Given this list of marker genes SLC39A4, TNFRSF11A, FOS, SLC39A5, SP1, BGLAP, SP7, here is a description of the gene set: Any process that results in a change in state or activity of a cell or an organism (in terms of movement, secretion, enzyme production, gene expression, etc.) as a result of a starvation stimulus, deprivation of zinc ion. studied in species Homo sapiens Human Gene Set: GOBP_RESPONSE_TO_ZINC_ION_STARVATION